Given this list of marker genes Itga3 (NCBI Gene Id 16400), Etv5, Egln3, Pkp2, Ccdc198, Krt84 (keratin 84), Tnnt2, Cldn6, Apoa2, Rnase4, Scarb1, Lsr, Ly75, Tpi1, Fam162a, Ap1m2, Snca, Apoc1, Krt19, Phlda2, Bex4 (brain expressed X-linked 4), Plcxd1, Ldha, Bex1, Shmt2, Aprt, Cyba, Pdzk1, Ccng1, Cbx7, Fkbp11, Prss8, Pfkl (phosphofructokinase, liver, B-type), Trim25, Dsg2, Myo7a, Tm4sf5, Slc16a3, Ero1a, Tspan8, Tagln2, Car7, Afp, Galk1, Amn, Aldob, Reep6, Ier3, Slc39a5, Spp2, Cldn2, Nherf1, Podxl, Plekha2 (NCBI Gene Id 97502), Ctsz, Lin28a, Slc13a4, Camsap3, Cgnl1, Trf, Lgals2, Ctsl, Bnip3l, Folr1, Kcne3, Adm, Aldoa, Alpk3, Grhpr, Spint1, Matn4, Aass, Has2, Hkdc1, Apoa4, Cdh1, Ezr, Renbp, Stard10, Myh7 (myosin, heavy polypeptide 7, cardiac muscle, beta), Arid3b, Upp1, here is a description of the gene set: studied in species Mus musculus Genes up-regulated in 9.5 days post coitus (dpc) embryos with COMMD1 knockout compared to normal 9.5 dpc embryos. from publication van de Sluis B, Muller P, Duran K, Chen A, Groot AJ, Klomp LW, Liu PP, Wijmenga C (PMID 17371845) COMMD1 (previously known as MURR1) belongs to a novel family of proteins termed the copper metabolism gene MURR1 domain (COMMD) family. The 10 COMMD family members are well conserved between vertebrates, but the functions of most of the COMMD proteins are unknown. We recently established that COMMD1 is associated with the hepatic copper overload disorder copper toxicosis in Bedlington terriers. Recent in vitro studies indicate that COMMD1 has multiple functions, including sodium transport and NF-kappaB signaling. To elucidate the function of Commd1 in vivo, we generated homozygous Commd1 null (Commd1(-/-)) mice. Commd1(-/-) embryos died in utero between 9.5 and 10.5 days postcoitum (dpc), their development was generally retarded, and placenta vascularization was absent. Microarray analysis identified transcriptional upregulation of hypoxia-inducible factor 1 (HIF-1) target genes in 9.5-dpc Commd1(-/-) embryos compared to normal embryos, a feature that was associated with increased Hif-1alpha stability. Consistent with these observations, COMMD1 physically associates with HIF-1alpha and inhibits HIF-1alpha stability and HIF-1 transactivation in vitro. Thus, this study identifies COMMD1 as a novel regulator of HIF-1 activity and shows that Commd1 deficiency in mice leads to embryonic lethality associated with dysregulated placenta vascularization. Mouse Gene Set: VANDESLUIS_COMMD1_TARGETS_GROUP_3_UP